Given this list of marker genes GSTO2, GLRX, GSTO1, GLRX2, GSR, here is a description of the gene set: Human Gene Set: GOMF_GLUTATHIONE_DISULFIDE_OXIDOREDUCTASE_ACTIVITY species: Homo sapiens Catalysis of the reaction: 2 glutathione + electron acceptor = glutathione disulfide + electron donor.